Given this list of marker genes PDIA5, KRT7, PKM, HSPA5, ACTG1, SERPINA1, PGAM1, KRT19, GRK4, MYCN (MYCN proto-oncogene, bHLH transcription factor), ACTB, ATP5F1D, FGF4, KRT8, CALU (NCBI Gene Id 813), EPHX1, P4HB, RAB14, KRT1, GFAP, ANXA1, GSTP1, ANXA8, PLCB3, PEBP1, PGK1, SOD2, HPRT1, here is a description of the gene set: Morphologic assessment of lung tumors is informative but insufficient to adequately predict patient outcome. We previously identified transcriptional profiles that predict patient survival, and here we identify proteins associated with patient survival in lung adenocarcinoma. A total of 682 individual protein spots were quantified in 90 lung adenocarcinomas by using quantitative two-dimensional polyacrylamide gel electrophoresis analysis. A leave-one-out cross-validation procedure using the top 20 survival-associated proteins identified by Cox modeling indicated that protein profiles as a whole can predict survival in stage I tumor patients (P = 0.01). Thirty-three of 46 survival-associated proteins were identified by using mass spectrometry. Expression of 12 candidate proteins was confirmed as tumor-derived with immunohistochemical analysis and tissue microarrays. Oligonucleotide microarray results from both the same tumors and from an independent study showed mRNAs associated with survival for 11 of 27 encoded genes. Combined analysis of protein and mRNA data revealed 11 components of the glycolysis pathway as associated with poor survival. Among these candidates, phosphoglycerate kinase 1 was associated with survival in the protein study, in both mRNA studies and in an independent validation set of 117 adenocarcinomas and squamous lung tumors using tissue microarrays. Elevated levels of phosphoglycerate kinase 1 in the serum were also significantly correlated with poor outcome in a validation set of 107 patients with lung adenocarcinomas using ELISA analysis. These studies identify new prognostic biomarkers and indicate that protein expression profiles can predict the outcome of patients with early-stage lung cancer. from publication Chen G, Gharib TG, Wang H, Huang CC, Kuick R, Thomas DG, Shedden KA, Misek DE, Taylor JM, Giordano TJ, Kardia SL, Iannettoni MD, Yee J, Hogg PJ, Orringer MB, Hanash SM, Beer DG (PMID 14573703) species: Homo sapiens Protein profiles associated with survival in lung adenocarcinoma. Human Gene Set: CHEN_LUNG_CANCER_SURVIVAL